The following is a description of a gene set: Human Gene Set: HP_APLASIA_HYPOPLASIA_INVOLVING_THE_PELVIS Aplasia/Hypoplasia involving the pelvis species: Homo sapiens, and this is the list of marker genes: CCN6 (cellular communication network factor 6), TRPV4, DDRGK1, TONSL, PIK3C2A, INTU, CFAP410, CHD4, XYLT1, CUL7, SLC26A2, GNPNAT1, RSPRY1, COL11A2, PEX5, SETBP1, FGFR3, FN1, CCDC8, MBTPS1, NSDHL, RSPO2, MMP9, TMEM67, COMP, CANT1, MTX2, EXOC6B, HSPG2, TRAPPC2, SMARCAL1, B3GALT6, IFNGR1, SLC10A7, COL9A1, TBX15, TBX4, IHH, SLC39A13, ERCC8, PORCN, NELFA, COL2A1, MATN3, FGFR2, IDUA, BMPR1B, CTC1, NSD2, INPPL1, TRAF3IP1, RAD21, LBR, SHOX, PRG4, MEG3, KAT6B, NANS, RUNX2, IFT140, ERCC6, WNT3, LETM1, CHST3, RTL1, CEP120, DLK1, PIGG, CPLX1, POP1, POC1A, ABCC9, AIFM1, OBSL1, CTBP1, WNT7A